Given this list of marker genes REV3L, VASP, PAICS, TRIM14, PRSS16, RPL39, TMEM131, CEP76, RGS13, LIF (NCBI Gene Id 3976), UCP2, RPL23A, PRG4, HPRT1, CLNK, DNAAF9, CASP8, GAB2, NEFH, ACP3, SERPINA4 (serpin family A member 4), PIK3CA, HSD17B4, SLC25A39, SLC36A4, DCK, HMG20A, SMAD1, RBBP4, CEP19, RBBP8, SUPT5H, ENOPH1, MVP, PSPH, GAS2L3, GALNT2, G6PD, FNIP2, OSBPL9, ADAD1, PRPF8, ASPM (NCBI Gene Id 93990), TXNDC5, RAPH1, EMC2, TEX10, HMGCR, STC2, SRP54, MPP1, CHSY1, DPYSL2, GRM4, TJP2, PCLAF, EN1, GSTM5, SFT2D2, IPO9, CHST11, SMU1, SEPTIN7, NLRC5, SULF2, PTGER2, MEGF9, COL19A1, PRR5L, CD53, PRIM2, RASL10A, UQCRB, ARMC7 (armadillo repeat containing 7), CAMK2B, TMEM109, SQOR, PLSCR4, ARSB, LAMTOR1, CBX1, PPP2R5E, ISL2, PLP2, STIL, HNRNPUL2, MRPL44, GALNT3 (NCBI Gene Id 2591), MAP1LC3B, CEP55, PDLIM1, ZC3H4, VEGFC, NOD1, RAP1A, PRKCH, LHFPL6, TGFBRAP1, STRN, LPIN2, SPATA21, CD200R1L, CD160, F2R, IGHG1, GALNT6, TMEM176A, RAB1A, TOPBP1, KCNAB2 (potassium voltage-gated channel subfamily A regulatory beta subunit 2), ECI2, SLC25A24, INTS6L, WASF2, CDCA5, RAB7A, GZMB, KIF18A, FAM89B, TCF7, PPP2R5A, SPRTN, SIKE1, FAM120A, STAT6, ITPK1, CLN3, CHP1, MED30, GYG1, FANCG, SNAP23, EEF2K, ARMCX4, RNF19A, TSPAN13, BRD9, C17orf58, CCNE2, CDC42BPG, COL6A3, STRN3, NR4A2, CNOT6, STX18, PPP1CB, LRRC75B, CRYBG1 (NCBI Gene Id 6763), THEMIS, ATP8B2, MYADM, LIMS4, PIK3CG, MORF4L1 (NCBI Gene Id 10933), DESI2, MARCKSL1, C9orf43, BECN1, TIMM44, CDC14B (NCBI Gene Id 8555), PREX2 (phosphatidylinositol-3,4,5-trisphosphate dependent Rac exchange factor 2), SMARCC1, IQGAP1, SAP30L, NSDHL, PSMB7, THY1, RALGAPB, SPRED2, SMC2, DUSP10, CUL1, PHACTR3, YWHAB, SMCO3, NDUFB11, TRAK1, PRDM1 (PR/SET domain 1), RRM2B, SET, SRI, PTPN12, YTHDF1, CDK6, ABCB7, ATP5F1C, ATP1B3, GOLM1, TLL1, HSPA4L, RELN, TGIF1, GOLPH3L, PXYLP1, TXNDC17, OTULINL, RAB3GAP2, TDRP, OMP, TPRG1L, here is a description of the gene set: Genes down-regulated in comparison of follicular B cells versus late germinal center (GC) B cells. Human Gene Set: GSE28237_FOLLICULAR_VS_LATE_GC_BCELL_DN studied in species Homo sapiens Upon immunization with a T cell dependent antigen naive follicular B cells (Fo) are activated and a germinal center reaction is induced. Within the next 2 weeks large germinal centers develop where the process of affinity maturation takes place. To analyze the gene expression profile of resting and activated B cells, follicular B cells (Fo), B cells from early (GC1) and late germinal centers (GC2) were isolated and their gene expression profile compared. from publication Wilke G, Steinhauser G, Grün J, Berek C (PMID 20518031)